Given this list of marker genes TMEM208, PPP1R10, ARG2, EIF2B2, IRF4, TUBD1, NAB2, RNF34, PTRH2, ZNF780A, CLDN1, C1orf56, IL23A, THUMPD3-AS1, RABIF, AMMECR1L (NCBI Gene Id 83607), SMIM7, NCBP1, KBTBD8, C14orf119, MIR3142HG, TTI2, ZNF250, ICOS, ID3, GAR1, PPIL1, GRAMD4, SPAG1, PLEKHO2, MFAP1, SPRY1, ZNF165, EGR4, VPS33A, IER5, BTG2, YIPF4, CCNH, TNFSF14, PTPN22 (protein tyrosine phosphatase non-receptor type 22), TXNDC15, TOB2, MRPL35, PRPF38A, NR4A3, BCLAF3, CHSY1, RALA, ZNF891, GLMN, ZFP82, MRPS18A, MCM6 (NCBI Gene Id 4175), NAB1, DUSP4, PAF1, LRR1, CKS2, SDF2, GADD45B, DCUN1D3, FYCO1 (NCBI Gene Id 79687), TP53RK, DNAJC27, RRAS2, ZFP69B, EVI2B, IBA57, ZNF416, GEM, FEN1, HCP5, PFKFB3 (6-phosphofructo-2-kinase/fructose-2,6-biphosphatase 3, NCBI Gene Id 5209), SLA, TNFSF9, ATG101, KCTD21, PUS3, TRAPPC4, ZNF557, YRDC, FBLN7, ZNF614, SH2D2A, MIR23AHG, LTA, MLX, C17orf100, MED21, ZNF140, TMEM60, NASP, ZNF443, SENP5, ARHGEF5, LINC01128, SNRNP35, NRIP3, MYNN, IFRD1, BTN2A2, EVI2A, LIG4, DUSP2, EGR1, WARS2, KLF10 (KLF transcription factor 10), COA4, GZF1, WDR36, AP5S1, EXOSC3, BCL10 (BCL10 immune signaling adaptor), ZNF200, SIPA1L1, CTSL, CCDC148, YWHAE, GPR183, SLFN11, CRNKL1, HMCES, NUBP1, FADD, SERTAD1, SDR42E1, ADO, BTLA, CREM, NFKBID, NKIRAS1, UTP11 (UTP11 small subunit processome component), ZPR1, CHAC2, TXNRD1, ISG20L2, NR4A1, CCRL2, DUSP18, IER2, NPC1, ATP2B1 (NCBI Gene Id 490, ATPase plasma membrane Ca2+ transporting 1), GPR65, SELENOS, FAM241A, TNF, MUL1, STARD3NL, MIR155HG, TIMM8A, STARD4, DUSP14, RRAGA, ERCC6 (ERCC excision repair 6, chromatin remodeling factor), EGR2, ZNF230, GEMIN6, PSMB5, ZNF713, TMEM88, FAM98A, ZNF506, PRDX1, CYCS, UMPS, C6orf120, TRAF3, TMEM127, ALG13, ENPP2, POLR3D, JAGN1, NAA30, GPR35, SLC35F5, ZBTB6, SLC25A32, TTC9C, ZNF410, SELENOK, TRMT10C, KPNA2, BCL2A1, CD200, SNAPC1 (NCBI Gene Id 6617), CYTIP, FAM177A1, NLRP3 (NLR family pyrin domain containing 3), MLYCD, TEX10, PHLDA1, PHF23, LIF, ANKHD1, TMEM243, here is a description of the gene set: Human Gene Set: GSE17974_0H_VS_1H_IN_VITRO_ACT_CD4_TCELL_DN The aim of this dataset was to study in detail the transcription kinetics initiated by cytokine IL-4 in early differentiation of Th2 cells. species: Homo sapiens Genes down-regulated in comparison of untreated CD4 T cells at 0 h versus the untreated cells at 1 h. from publication Elo LL, Järvenpää H, Tuomela S, Raghav S, Ahlfors H, Laurila K, Gupta B, Lund RJ, Tahvanainen J, Hawkins RD, Oresic M, Lähdesmäki H, Rasool O, Rao KV, Aittokallio T, Lahesmaa R (PMID 20620947)